The following is a description of a gene set: part of: Cell-Cell communication studied in species Homo sapiens Reactome Pathway: Cell junction organization, and this is the list of marker genes: PSMB6, CDH9, ARID1A, SRC, H3-3A, PARVA, TNRC6C, PARD6G (par-6 family cell polarity regulator gamma), UBA52, TYK2, HDAC1, MIR451A, PARVB, AFDN, NFKB1, MOV10, TRAF7, KLF9, PSMC1, PKM, LIMS1, PSMD11, PSMD7, PSMC6, H2BC12, CDH6, H2AC6, PRKCSH, ELMO1, CDH24, CLDN5, VASP, ANG, RB1, PSMD12, MIR9-2, ILF3, FOXQ1 (forkhead box Q1), STT3A, ITGB1, ADAM19, FBLIM1, CLDN7, OST4, CADM2, PSMD6, CDH3, H2BC3, CLDN23, CDH10, H2AC7, FOXP2, UBB, WT1, DST (dystonin), AGO2, H2AB1, CTSL, HOXC8, SIRT1, H2BC21 (NCBI Gene Id 8349), ARHGEF4, PSMA3, COL17A1, FLNC, CDH1, NECTIN1, SNAI1, PSMB2, TWIST1, TFAP2A, PCSK7, NECTIN3, PLEC, HDAC2, MAPK3, FOXA2, KLF4, PSMA1, H2AJ, LAMC2, CTBP1, CLDN9, CLDN14, FOXJ2, OSTC, CLDN3, CDH5, JAK1, PSMB4, DNM2, PSMA5, H2BC26, PSMC5, SMARCA4 (NCBI Gene Id 6597), IL6ST, FERMT2, PARD3, TCF3, SDK2, FURIN, VAV2, H2BC4 (H2B clustered histone 4), ZNF217, SEC11C, MIR9-3, PSMD13, CSNK2A3, KRT14, CRB3, CTBP2, CLDN20, ITGA6, SPCS2, CDC42, KRT5, PSMB5, NECTIN2, H2BC12L, H2BC13, ACTG1, CLDN15, PSMD3, RNF19B, CDH15, H2AC20, CLDN16, ANK3, H2AC18, ACTG2, H2BC1, PRDM8, F11R, CLDN19, H2BC17, MIR200C, PATJ, ZEB2, PSMA2, CADM1, TMEM258, ZC3H12A, H3C15, GANAB (glucosidase II alpha subunit), RACK1, ZBTB33, PSMD2, ACTC1, CLDN18, UBC, CLDN2, TCF12, CDH2, RELA, LAMB3, PXN, KMT5A (NCBI Gene Id 387893), CTNNA1, FARP2, CLDN8, TIAM1, PSMA7, TLE1, CANX, CDH12, RSU1, BANP, SP1, FLNA, RBBP4, RPS27A, CLDN6, CTNND1, RAC1, CLDN11, CDH11, IL6R (interleukin 6 receptor), PSMC2, PSMA4, SUZ12, CDH13, ILK, PCSK6, CLDN4, TNRC6A, PSMD8, SDK1, RPN2, MIR9-1, PSMD14, POMT2, EZH2, H4C1, PARD6A, TESK1, AGO4 (NCBI Gene Id 54791), CBLL1, ACTA1, ADRM1, IL6, PRKCI, MIR10B, PVR, PSMC4, H2AC4, PARD6B, CLDN1, SEC11A, ZMYM2, STAT3, CSNK2A2, ITGB4, H2AZ2, PSMA6, CTSB, DAD1, H2BC9, MCRIP1, H2BC14, RBBP7, RPN1, DNTTIP1, KDM1A, PSMB1, PSMD1, HEYL, HACE1, ANGPTL4, SPCS1, H2AX, JAK2, VCL, PSMB3, MDM2, CADM3, TWIST2, CSNK2A1, UCA1, H3C1, BHLHE22, H2BC11, CDH8, H2BC15, CLDN17 (claudin 17), CTSS, TGIF2, NECTIN4, AGO3, DDOST, MAPK1, PSMB7, XIAP, LIMS2, CLDN12, E, SOX10, ACTN1, MPHOSPH8, ADAM33, SEM1, MYC, DOCK1, TNRC6B, LAMA3, FYN, MTBP, CDH18, AGO1, ZEB1, CD151, CLDN22, ACTA2, PALS1, SPCS3, CDH17, CDH4, AMOT, ARHGEF6, POMT1, BIRC2, CSNK2B, STRAP, ARHGAP32, MYCN, H2AC14 (NCBI Gene Id 8331), CLDN10, EPS15, FOXF1, SNAI2, MOGS, CDH7, ACTB, CDH19, JUP, PSMC3, CTNNB1, EED, PIP5K1C, H2BC5